The following is a description of a gene set: Genes predicted to be targets of miRBase v22 microRNA hsa-miR-3169 in miRDB v6.0 with MirTarget v4 prediction scores > 80 (high confidence targets). species: Homo sapiens from publication Chen Y, Wang X (PMID 31504780) Human Gene Set: MIR3169, and this is the list of marker genes: ATG12, NKAP (NCBI Gene Id 79576), FERMT1, SMARCA1, CIP2A, GIPC2, DNMT3A, NRSN1, IVNS1ABP, GNG5, HTR3E, INO80D, CALCOCO2 (calcium binding and coiled-coil domain 2), NKX2-4, CCDC121, ASB8, RALA, NRP2, ZHX2, ENPP1, SLC22A1, PIK3R3, GOLPH3, ZNF701, C16orf46, SMG1, LIN54, ATF2, ELOVL6, B3GAT1, OR7A5, HCLS1, SOD2, RAP2C, ZXDA, TMCC1, PSD3, DTHD1, NAA50, CNBD2, SORBS1, SUN1, NIPAL2, PRICKLE1, CHRNA1, GNG4 (G protein subunit gamma 4), RAB26, SPG11, TMEM175, ZBTB10, PNLDC1, REDIC1, FGF13 (fibroblast growth factor 13), TPM1, MTMR4, ZNF813, ARID3B, TGIF2, FIGN, PAPPA, COMMD8, CSRNP3